The following is a description of a gene set: Peripheral retinal atrophy Human Gene Set: HP_PERIPHERAL_RETINAL_ATROPHY species: Homo sapiens, and this is the list of marker genes: TRNT1, SLC6A6, MERTK, RBP4, RPGRIP1